The following is a description of a gene set: Bridging together two regions of a DNA molecule. studied in species Homo sapiens Human Gene Set: GOMF_DNA_DNA_TETHERING_ACTIVITY, and this is the list of marker genes: MSL2, PCBP2, CASC11, CTCF, RUVBL2, AHDC1